The following is a description of a gene set: from publication Jiang S, Li C, Olive V, Lykken E, Feng F, Sevilla J, Wan Y, He L, Li QJ (PMID 21972292) miR-17 from the miR-17-92 cluster regulate activation-induced cell death in T cells and modulate inducible regulatory T cell differentiation. We used microarrays to detail the global program of gene expression modulated by miR-17 and aim to identify the potential targets of miR-17. studied in species Homo sapiens Genes down-regulated in activated CD4 T cells: wildtype versus over-expressing MIR17. Human Gene Set: GSE32533_WT_VS_MIR17_OVEREXPRESS_ACT_CD4_TCELL_DN, and this is the list of marker genes: LAMA2, APOBEC2, TXLNB, TMPRSS13, TMEM8B, ATP5F1A, CXCL13, ZFTA, USP42, CABCOCO1, ZNF511, TMT1A, NDUFS1, GPC4, PLXNB1, MYBPHL, EHBP1, NKD1, DEAF1, HADH, ESRRB, MAOB, IDH3G, PPL, INPP5A, SYNPO2, TSPYL5, MYPN, BVES, OPN4, SERPING1, HSPB2, EDAR, CCSER2, ACBD4, FHIP1A, LMOD2, CARNS1, CMYA5, LGR6, ATP5MC1, FNDC5, DNTTIP1, ARHGEF25, RBM24, RCAN2, INSR, TMEM182, LIMCH1, PYGM (NCBI Gene Id 82368), SGCA, TCEA3, MLANA, MDH2, ETFDH, GSTK1, DRGX, MACROD1, DRD1, FH, TMEM163, DPYSL5, PDZK1, CAMK2N1, HSPB8, GNAO1, KCNJ3, SBDS, PCSK6, FMC1, TUBG2, FAM131A, CASQ2, DOCK6, C4orf54, VAMP5, MB, PXDC1 (PX domain containing 1), ABLIM3, ABCC8, WDSUB1, PPARA, ATP1A2, ACTC1, WNT9A, RASEF, ECHDC2 (NCBI Gene Id 55268), RGS17, ACADM, LIN7A, AXIN2, MTRES1, PPARGC1A, SLC47A1, VSIG4, KLHL30, ITGB1BP2, GABRB1, MYOZ2, PHYH, AGTR1, ARHGEF37, DPYD, EPHA4, CSRP3, MYLK3, POPDC2, BAG2, SVIP (small VCP interacting protein), ITIH5, PRKG1, SLC25A4, WSCD1, RPS6KA6, STK39, PRKAA2, ADHFE1, MTURN, ESRRG (NCBI Gene Id 2104), HOXC8, APOD, CAV1, PGM5, ENTPD5, MYOC, ING3, SIDT2, GUCY1A1, ADPRHL1, FGFRL1, DKK1, ACAT1, STARD10, TNNT1, SMPX, ALDH6A1, CLDN12, LDHB, MBOAT2, CDC73 (cell division cycle 73), SYTL2, CALR3, HSPB6, PDHA1, KLHL13, CES1, PPP2R3A, ATP5F1D, SLN, RYR2, KBTBD13, LAD1, PODN, MYL4, RHBDL3, MLXIPL, IGF2, PTPDC1, TNNI3, ART3, ALPK2 (NCBI Gene Id 115701), URB1, THRA, GPI, PIP5K1B, FDX1, MYL1, LDB3, ZYG11B, CRIP2, SEPTIN4, PFKM, NKX6-2, ASB11, ARMH4, MYLK4, FXN, HHATL, PARN, PDGFRL, SGCG, VSTM4, SPTBN1, SYDE2, NEXN, DLC1, RRAD, GPC1 (NCBI Gene Id 2817), COX6A2, AMY2A, CAP2, MYL7, PTPRK, IQCB1, CFL2, EBF4, NTSR2, FRMD6, ZNF628, PAIP2